Given this list of marker genes Upp2, Nt5c3, Upb1, Dpyd (dihydropyrimidine dehydrogenase), Nt5c, Upp1, Dpys, here is a description of the gene set: studied in species Mus musculus The chemical reactions and pathways resulting in the breakdown of UMP, uridine monophosphate. Mouse Gene Set: GOBP_UMP_CATABOLIC_PROCESS